The following is a description of a gene set: Human Gene Set: GOBP_NEGATIVE_REGULATION_OF_FATTY_ACID_TRANSPORT Any process that stops, prevents, or reduces the frequency, rate or extent of fatty acid transport. species: Homo sapiens, and this is the list of marker genes: PLA2R1, FIS1, CYP4F2, AKT1, ACSL4, IRS2, AKT2, THBS1